Given this list of marker genes BAK1, ATP1A4, FXYD2, ATP1A1, ATP12A, SLC22A1, ATP1A2, ATP1B1, BAX, ATP1A3, ATP4A, here is a description of the gene set: The directed movement of ions to establish or maintain an electrochemical gradient across a membrane by means of some agent such as a transporter or pore. Human Gene Set: GOBP_ESTABLISHMENT_OR_MAINTENANCE_OF_TRANSMEMBRANE_ELECTROCHEMICAL_GRADIENT species: Homo sapiens